Given this list of marker genes Apobec2, Apobec3, Apobec4, here is a description of the gene set: Reactome Pathway: mRNA Editing: C to U Conversion electronically inferred by orthology from the curated human pathway part of: mRNA Editing This event has been computationally inferred from an event that has been demonstrated in another species.<p>The inference is based on the homology mapping from PANTHER. Briefly, reactions for which all involved PhysicalEntities (in input, output and catalyst) have a mapped orthologue/paralogue (for complexes at least 75% of components must have a mapping) are inferred to the other species. studied in species Mus musculus